Given this list of marker genes Uvrag, Reep3 (NCBI Gene Id 28193), S100a6, Arhgef2, Ankrd35, Arhgap5, H1f2, Nfkbid, Parp8, Hivep1, Limd2, Mycbp2, Hck, Lmo4, Rassf4, Clip1, Adam23, Dynll2, Fos, St8sia1, Rgs3, Fyb1, Pgap2, Csf1, Stk4, Cyria, Cdk17, Zeb2, Pde4a, Phf11b, Arhgap31, Fus, Ankrd33b, Sulf2, Swap70, Vrk2, Stoml1, Ptpn6, Adam11, Ttc7, Trim7, Gbp9, Traf2, Ero1b, Ccdc88a, Crip1, Hmgcs1, Rsrp1, Atf7ip (activating transcription factor 7 interacting protein), Thap2, Hspa1a, Cep57, Usp18, Ly86, Itgb8, Nup210, Socs2, Dpp4, Icosl, Traf1 (NCBI Gene Id 22029), Jag1, Cacnb3, Clec2i, Gbp8, Ddhd1, Cdk12, Mical3, Gsto1, Kdm2b, Btg2, Rubcn, Nabp1, Adap1, Fuca1, Irag2 (inositol 1,4,5-triphosphate receptor associated 2), Sqstm1, Fgd2, Gtpbp1, Ppp4r2, Icam1, Etv3, Gpr68, Sesn3, Specc1 (sperm antigen with calponin homology and coiled-coil domains 1), Extl1, Tmem176b, Gpc1, Jun (jun proto-oncogene), Galnt1, Hspa1b, Taok3, Zc3h12c, Gfpt1, Sema6d, Ythdf2, Bmp2k, Tmcc3 (NCBI Gene Id 97668), Nrbf2, Glipr1, Ap1s3, Xist, Slc66a2, Rasa4, Slco5a1, Arhgap22, Rcsd1, Eno3 (NCBI Gene Id 13808), Csf2rb2, Klf2, Clec2d, Trio, Pygl, Tcf7l2, Trps1, Sdc3, Vhl, Ndnf, H2ac25, Cd52, Cyp27a1, Arhgef6, Zfc3h1, Brk1, Nav1, Mylip, Idh1, Cyfip2, Ehmt1, Phf21a, Evi2a, Elk3 (NCBI Gene Id 319474), Tank, Fbrsl1, Creg1, Tmx3, Rbpj, Adm, Cbfa2t3, Apol10b, Il15, Dlgap4, Rspry1, Arhgdib, Casp3, Pbx1 (pre B cell leukemia homeobox 1), H2bc4, Blnk (NCBI Gene Id 17060), Cblb, Nfat5, Chka, Unc93b1, Tnfrsf11a, Mxd1, Slc20a1, Fosb, Anxa3, Relb, Nxf1, Sc5d (NCBI Gene Id 319312), Dnm1l, Mark3, Peak1, Itfg1, Cpne2, F11r, Hmgcr, Camta2, Slc46a3, Stard7, Sh3bp1, Nedd4, Dek, Tnfrsf1b, Grk3, Plxnc1, Sik2, Frmd4a, Arhgap45, Mx1, Kmt2e, Eno2, Ppp1r15a, Gtf2a1, Jmjd1c (jumonji domain containing 1C), Sbno2, Tmem158, Tmem176a, Tmem19, Fmnl2, Arl5a, St8sia6, Rogdi, Colgalt1, Man1a, Ucp2, Slc38a2, Lst1, Dtx3, Dock2, Mtmr4, Pot1b, H2-M2, Uqcc2, Tubb5, Rptor, Grn, Lnpep, Stk38, Cyba, Gpr157, Zfp36l1, Cflar, Hlx, Slc6a6, Atxn1, Mfge8, Cmtm7, Snrnp25, Insm1, Laptm5, Prrc2b, Tspan33, Cdc42ep3, Tuba1c, Sat1, Gbp4, Abcg1, Asap1, Ankrd13a, Sgk3, Vps13a, Dync1h1, Emp3, Nuak1, Synpo2, Galnt12, Cat, Wdr91, Apol7c, Tmem150c, Sertad2, Peli1, Got2, Haus8 (4HAUS augmin-like complex, subunit 8), Ctsh, Eps15, Smg1, Csrnp1, H2-Q6, Rtn4, Celf2, Lyst, Mef2a, Ptpn21, here is a description of the gene set: Genes negatively differentially expressed in cell type: MigDC (migratory dendritic cell) upon treatment with cytokine: IL-1α in mouse lymph nodes in vivo. from publication Cui A, Huang T, Li S, Ma A, Pérez JL, Sander C, Keskin DB, Wu CJ, Fraenkel E, Hacohen N (PMID 38057668) studied in species Mus musculus Mouse Gene Set: CUI_MIGDC_IL1A_RESPONSE_DN Cytokines mediate cell-cell communication in the immune system and represent important therapeutic targets. A myriad of studies have highlighted their central role in immune function, yet we lack a global view of the cellular responses of each immune cell type to each cytokine. To address this gap, the authors created the Immune Dictionary, a compendium of single-cell transcriptomic profiles of more than 17 immune cell types in response to each of 86 cytokines (>1,400 cytokine-cell type combinations) in mouse lymph nodes in vivo. A cytokine-centric view of the dictionary revealed that most cytokines induce highly cell-type-specific responses. For example, the inflammatory cytokine interleukin-1β induces distinct gene programmes in almost every cell type. A cell-type-centric view of the dictionary identified more than 66 cytokine-driven cellular polarization states across immune cell types, including previously uncharacterized states such as an interleukin-18-induced polyfunctional natural killer cell state.